Given this list of marker genes NONO, RLIM, AP4B1, AP4S1, FERRY3, POLA1, DPYD, AP4M1, AP4E1, TAF4, FMR1 (NCBI Gene Id 5421), SETD2, here is a description of the gene set: Excessive shyness Human Gene Set: HP_EXCESSIVE_SHYNESS Atypically high degree of awkwardness or apprehension experienced when approaching or being approached by others. species: Homo sapiens